The following is a description of a gene set: Hepatic graft versus host disease (GVHD), day 7: down-regulated in allogeneic vs syngeneic bone marrow transplant. Mouse Gene Set: ICHIBA_GRAFT_VERSUS_HOST_DISEASE_D7_DN species: Mus musculus from publication Ichiba T, Teshima T, Kuick R, Misek DE, Liu C, Takada Y, Maeda Y, Reddy P, Williams DL, Hanash SM, Ferrara JL (PMID 12663442) The liver, skin, and gastrointestinal tract are major target organs of acute graft-versus-host disease (GVHD), the major complication of allogeneic bone marrow transplantation (BMT). In order to gain a better understanding of acute GVHD in the liver, we compared the gene expression profiles of livers after experimental allogeneic and syngeneic BMT using oligonucleotide microarray. At 35 days after allogeneic BMT when hepatic GVHD was histologically evident, genes related to cellular effectors and acute-phase proteins were up-regulated, whereas genes largely related to metabolism and endocrine function were down-regulated. At day 7 after BMT before the development of histologic changes in the liver, interferon gamma (IFN-gamma)-inducible genes, major histocompatibility (MHC) class II molecules, and genes related to leukocyte trafficking had been up-regulated. Immunohistochemistry demonstrated that expression of IFN-gamma protein itself was increased in the spleen but not in hepatic tissue. These results suggest that the increased expression of genes associated with the attraction and activation of donor T cells induced by IFN-gamma early after BMT is important in the initiation of hepatic GVHD in this model and provide new potential molecular targets for early detection and intervention of acute GVHD., and this is the list of marker genes: Rpl22, Hmgcs2, Sc5d, Reln, Papss2, Mup4, Cryl1, Prom1, Lipc, C8g, Pom121, Hba-ps3, Serpina6, Mir294, Lifr, Cela1, Cyp4a10, Acaa1b, Nat8f1, Prm3, Hes6, Hbb-bs, Slc26a1, Igha, Me1, Sult4a1, Mup3, Mup1, Mup5, Dio1, G6pc1, Slc25a10, Pklr, Ghr, Yju2, Nxn, Actl7b, Elovl6, Alas2, Tenm3, Cyp4a31, Cdc5l, Igkv17-127, Exosc8, Prlr, Adgrl1, Acaa1a, Glns-ps1, Cyp2b13, Hsd17b2, Cyp2b9, Uck1, Osbpl5, Elovl2, Rdh16